The following is a description of a gene set: Binding to a specific upstream regulatory DNA sequence (transcription factor recognition sequence or binding site, located in cis relative to the transcription start site (i.e., on the same strand of DNA) of a gene transcribed by some RNA polymerase. Cis-regulatory sites are often referred to as a sequence motifs, enhancers, or silencers. Mouse Gene Set: GOMF_CIS_REGULATORY_REGION_SEQUENCE_SPECIFIC_DNA_BINDING species: Mus musculus, and this is the list of marker genes: Hoxa2, Zfp942, Zbtb7a, Obox7, Zbtb25, Tcf7l1, Sox17, Rax, Nr3c2 (NCBI Gene Id 17363), Gm12258, Hoxb6, Zfp663, Smc3, Irf1, Zfp853, Klf6, Dmtf1l, Olig2, Etv6, Snapc3, Tbx6, Creb3l2, Hoxa1, Batf, Zfp74, Zfp869, Zfp54, Kdm1a, Tug1, Rest, Dlx1, Gzf1 (GDNF-inducible zinc finger protein 1), Atoh8, Pparg, Zscan21, Zfp704, Hoxc9, Wbp2, Zbtb17, Foxa2, Blvra, Zkscan3, Neurod6, Nr2c2, Nkx2-3, Rel, Notch2, Stk16, Rxrb, Zbtb43, Foxp3, Meox1, Foxp2, Zscan22, Cebpe, Foxd2, Snai1, Foxb2, Yap1, Zbtb14, Pitx3, Tal2 (T cell acute lymphocytic leukemia 2), Nfe2l1 (nuclear factor, erythroid derived 2,-like 1), Evx1, Sox9, Hdac5, Myod1, Atf6, Zfp39, Mtf1, Zbtb2, Otx1, Srebf1, Creb3, Zfp3, Tcf12, Etv2, Hoxd9, Hinfp, Hnf4a, Srf, Onecut1, Ets2, Myog, Sox6, Crem, Ell, Figla, Hmga1, Tfec, Foxc2, Rarg, Onecut2, Zfp507, Hoxd4, Nfe2l3, Bcl11b, Foxn3, Bmal1, Zfp975, Foxe3, Cc2d1b, Mef2b, Atf7, Stat4, Mybl2, Cdx1, Cux1, Myb, Zeb1, Skor2, Zfp444, Zfp446, Hnrnpk, Tgif1, Egr1, Klf1, Pax4, Calcoco1, Neurog3, Rbmxl1, Klf16, Bsx, Mypop, Litaf, Ovol3, Hoxa11, Sars1, Ovol1, Zbtb45, Zfp868, Zfp384, Ubp1, Runx2, Zbtb24, Gm14418, Foxo1, Zfp775, Stat6, Zfp280d (zinc finger protein 280D), Sox1, Mxi1, Bhlhe40, Nacc1, Pasd1, Helt, Clock, Zfp30, Zfp644, Tbx2, Fosl2, Patz1, Pax3, Zfp707, Eef1d, Sp140, Zfp358, Hif1a, Hnrnpu, Smad5, Vax2, Sp6, Lrrfip1, Nfyc, Hdx, Zfp935, Rfx4, Mynn, Zfp984, Thrb, Hdgf, Thap1, Fezf2, Zfp418, Hivep1 (NCBI Gene Id 15271), Esr2, Otx2 (orthodenticle homeobox 2), Zfp53, Msx2, Hmga1b, Zeb2, Six5, En2 (engrailed 2), Stat2, Dmrta1, Zfp612, Tfcp2, Zfp219, Ascl1, Nrf1, Gli3, Zfp286, Nr2e1, Mixl1, Zscan20 (NCBI Gene Id 277652), Foxn2, Hoxb9, Prmt5, Hoxd13, Zfp534, Rora, Ppara, Hsf2, Nkx3-2, Zbtb6 (zinc finger and BTB domain containing 6), Zfp689, Rxra, Prdm16 (NCBI Gene Id 70673), Zkscan14, Hoxd1, Brf1, Zscan4d, Med1, Ccar1, Foxo4 (NCBI Gene Id 54601), Zfp395, Gcm2, Zfp213, Rorb, Prox1, Mxd4, Kdm6b, Nfya, Zfp747l1, Tfap2e, Dach1, Zkscan2, Foxa1, AW146154, Neurog2, Pou4f2 (NCBI Gene Id 18997), Cxxc1, Tfap4, Hoxa3, Zbtb20, Zfp13, Zbtb7c, Gm2381, Hey2, Gm7072 (predicted gene 7072), 4930522L14Rik, Foxa3, Maf1, Gm4767, Mef2d, Zscan26, Zfp128, Zfp143, Zfp560, Mlxipl, Zfp563, Zfp809, Fezf1, Nkx6-1, Hoxa5, Msx1, Zbtb12, Zfp648 (NCBI Gene Id 207678), Tbx22, Plag1, Ski, Mef2a, Zfp937, Nfe2, Zfp985, Wiz, Zbtb1, Hes2, Zfp992, Hoxc4, Gtf2ird1, E4f1, Mtor, Foxf2, Thrap3, Pou1f1, Tiparp, Scrt2, Cebpb, Evx2, Onecut3, Zbtb37, Creb5, Zfp160, Zfp874a, Ascl2, Zfp871, Ikzf2, Zfp341, Zfp683, Glis2, E2f6, Zfp954, E2f7, Thap11, Nr4a1, Nkx2-5, Smad4, Relb, Zfp772, Twist1, Sp3, Fev, Zscan4c, Phox2b, Nfatc2, Dach2, Zfa-ps, Zbtb26, Atoh1 (NCBI Gene Id 11921), Ezh2, Zfp768, Myf5, Zic4, Pou3f2, Nr2f6, Foxn4, Ehf, Tcf15, Isl1, Nr2c1, Prdm5, Zfp141, Zbtb11, Nrl, E2f2, Zik1, Bptf, Tfap2a, Tbx5, Zfp973, Pou3f3, Pax6, Foxd4, Zscan10, Per2, Zfp366, Pou6f1, Fubp1, Zfp970, Zfp946, Sirt1, Cebpa, Ddit3, Zbtb7b, Zfp879, Dmrtc1b, Nkx2-9, Gm19965, Tet1, Rslcan18, Irf3, Smad9, Hoxb5, Klf5 (Kruppel-like transcription factor 5), Zfp980, Vax1, Zfp174, Maff, Gsx1, Nr1i2, Isl2, Ctcf, Nkx1-1, Ep300, Hoxa4, Sohlh1, Rad21, Tead4, Fli1, Zfp988, Nrip1, Nfe2l2, Sall1, Zfp263, Spib, Ascl5 (achaete-scute family bHLH transcription factor 5), Sox3, Rsl1, Bcl6b, Thra, Spz1, Skor1, Mafa, Zfp260, Nkx2-6, Nkx2-1, Zfp773, Hesx1, Zfp623, Zfp1, Zfp583, Hnf4g, Zfp740, Hif3a, Runx1, St18 (suppression of tumorigenicity 18), Dmrt1, Klf10, Tbx10, Nfkb1, Bach2 (NCBI Gene Id 319905), Dmrtc1a, Wt1, Foxl2, Plagl1, Sox13, Zfhx4, Zfp977, Zkscan17, Klf12 (Kruppel-like transcription factor 12), Zfp866, Klf13, Zfp239, Foxe1, Zfp131, Tfeb, Rorc, Hoxb4, Bach1, Foxl1, Arnt2, Hes7, Tbx15, Mafk, Zfp599, Trim24, Egr3, Bhlhe41, Zfp994, Zfp28, Prdm15, Bhlhe23, Spi1, Dbp, Trp73, Zfp354a, Klf9, Zfp87, Zfp354b, Zfp940, Zscan29, Zfp322a, Meis1, Sox2, 5730507C01Rik, Zfp668, Obox3, Zfp846, Irf8, Gtf3c5, Trp63, Hoxa13, Tcfl5, Hes1, Zfp990, Zfp870, Zfp454, Notch4, Foxs1, Hnf1b, Zfp750, Nr2e3, Gm6871, Nr1i3, Mafg, Zfp930, Zfp712, Suz12, Irf2, Hoxd11, Zkscan4, Zfp287, Bmyc, Tcf7l2 (NCBI Gene Id 21416), Pbx1, Zfp280b, Med12 (mediator complex subunit 12), Zfp983, Tfap2b, Tbp, Zfp764, Jun, Mzf1, Prdm11, Gata6, Zfp989, Hoxa9, Zfp865, Stat1, Egr4, Dlx2, Hhex, Crx (cone-rod homeobox), Klf14, Nr2f1, Cdx4, Zfp72, Klf17, Foxo3, Zscan4-ps1, Jmjd8, Zfp82, Grhl1, Emx2, Zfp92, Zfp84, Zscan25, Nhlh2, Zbtb33, Zfp551, Zfp335, Ebf3, Sox18, Hoxc5, Zfp113, Nr1d2, Zfp148, Mecom, Zfp442, Tbx19, H3f3a, Smad3, Zic1, Ncoa2, Pax8, Tcf4, Yy1, Zfp345, Zfp580, Zfp998, Mnt, Gm14403, Zfp456, Zbtb22, Klf8, Zbtb9, Eomes, Zfp575, Pou2f1, Hoxb7, Top1, Zbtb49, Zfhx3 (zinc finger homeobox 3), Zkscan16, Zfp934, Prox2, Nkx6-3, Sox21, Gmeb2, Zfp354c, Hdac6, Zfp960, Glis3, E2f3, Msc, Tet3, Zfp273, Hsf1, Zfp568, Irx2, Med8, Grhl2, Tfdp1, Tbx18, Ikzf3, Foxf1, Ell3, Hmga2, Ctcfl, Neurod1, Nsd1, Hes3, Dmrtc2, Sox11, Glis1, Nfib, Zfp655, Jund, Zfp746, Satb1 (special AT-rich sequence binding protein 1), Zfp1004, Zfp715, Elk3 (ELK3, member of ETS oncogene family), Nr1h4, Zfp280c, Lhx1 (LIM homeobox protein 1), Sox30, Zfp667, Rfx5, Zfp516, Smyd3, Obox1, Usf1, Zfp820, Prrx2, Dhx36, Dhx9, Obox2, Hey1, Hoxc11, Bcl11a, Ell2, Dnmt3a, Gsc2, Smad2, Irf6, Batf2, Ppard, Nkx2-4, E2f4, Irx1, Gata5 (NCBI Gene Id 228988), Zfp110, Nr2f2, Nfkbiz, Tal1, Nkx1-2, Irf7, Kcnip3, Pou4f1, Creb3l3, Bhlha15, Runx3, Notch1, Zfp212, Pou6f2, E2f1, Elk1, Hmgb2, Irf4, Zfp872, Zfp639, Zfp943, Meis2, Cebpd, Tbx4, Yy2, Zfp277, Dmrt2, Hsf4, BC024063, AI854703, Gcm1, Zfp352, Zfp369, Noto, Zfp410, Dlx5, Zfp7, Maz, Dmtf1, Mir208b, Xbp1, Hes6, Irx4, Ikzf5, Nfat5, Zfp513, Zfp995, Foxj1, Sox12, Zfp607a, Atf4, Zfp251, Mybl1, Mitf, Sox8, Foxc1, Mycs, Sp4, Rfx7, Ikzf4, Npas4, Zfp982, Nr5a1, Per1, Tead3, Sox5, Ovol2, Nkx3-1, Pax2, Arx, Gata1, Zfp697, Zkscan7, Pou2f2, Nkx6-2, Snai2, Nr3c1, Zic2 (NCBI Gene Id 57066), Bmal2, Zfp933, Emx1, Nr1h2, Hivep3, Gm32687, Zfp652, Zfat, Myt1l, Zbtb16, Zfp65, Esrrg, Zfp426, Sp7, Pgr, Zfhx2, Sohlh2, Pou3f1, Snapc4, Ikzf1, Myt1, Rfx2, Fos, Zbtb32, Zim1 (NCBI Gene Id 22776), Pitx1, Pbx3, Hdac1, Zfp991, Kdm6a, Nfil3, Nr1d1, Cry1, Satb2, Zbtb8a, Gli2, Zfp296, Irx3, Zbtb39, Elf4, Atf2 (activating transcription factor 2), Cphx1, Zfp987 (zinc finger protein 987), Zfp637, Ets1, Mef2c, Prop1, Arnt, Zfp68, Gm15446, Lyl1, Gm17655, Zfp647, App (NCBI Gene Id 319425, amyloid beta precursor protein), Zfp981, Mycl, Pou4f3, Zfp944, E2f8, Zfp711, Zfp708, Muc1, Zfp1007, Sox7, Brf2, Six4, Gm14434, Mxd3, Zfp536, Insm2, Zfp976, Pax1, Zic3, Klf4, Pdx1, Hand2, Insm1, Hoxd3, Foxj2, Fosb, Smad1 (NCBI Gene Id 17125), Mkx, Irf5, Irx6, Hoxc10, Tcf3, Zfp429, Hlf, Tcf21, Obox5, Ogg1, Prdm1, Nobox, Pitx2, Snai3, Nr1h5, Zscan4e, Hnf1a, Myef2, Nkx2-2, Foxd1, Uhrf1 (NCBI Gene Id 18140), Ruvbl2, Safb, Sox14, Obox8, Myf6, Gata4, Ahr (NCBI Gene Id 193333), Zbtb4, Zfp692, Stat5a, Zkscan5, Klf7, Klf15, Rbmx, Mga, Hoxd10, Pax7, Pknox1, Preb, Foxq1, Zfp932, Zfp1006, Pou5f1, Esrra, Zfp281, Zfp874b, Zgpat (NCBI Gene Id 229007), Rfx8, Meox2, Hoxc13, Sp8, Zfp362, Mesp2, Usp3, Tbx21 (T-box 21), Pax5, Atf3, Creb3l1, Sp2, Zfp184, H2az1, Zfp202 (NCBI Gene Id 80902), Stat5b, Carf, T, Zbtb38, Hdac2, Zfp966, Zfp408, Zfp941, Neurod2, Nhlh1, Nfyb, Zfp607b, Ptf1a, Lef1, Zfp58, Foxj3, Scrt1, Npas2, Mafb, Junb, Hoxc6, Ddn, Klf3, Neurod4, Rbpjl, Zfp182, Ebf4, Gm5141, Zscan5b, Hdac4, Rfx6, Jdp2, Hoxb2, Zfp850, Creb1, Six1, Nr4a3, Etv4 (NCBI Gene Id 217208), Gmeb1, Zfp947, Hbp1, Nfatc3, Zfp979, Spic (Spi-C transcription factor (Spi-1/PU.1 related)), Tbx1, Zscan12, Gfi1b, Kcnh8, Zfp236, Esrrb, Nfic, Nr5a2, Hoxb1, Hoxa6, Tef, Usf2, Sub1, Nr6a1, Chd7, Dmrta2, Zfp397, Nfkb2, Zscan4-ps2, Zfp677, Sp9, Zfp873, Dlx3, Gabpa, Zfp821, Hoxb13, Neurog1, Zfp2, Zfp334, Maf, Tead1, Zfp628, Pou3f4, Zfp433, Esr1, Foxi1, Rbpj, Zfp951, Atf6b, Mesp1, Zfp386, Prdm4, Heyl, Zfp455 (zinc finger protein 455), Zfp958, Sox15, Gata2, Mycn, Chd2, Tbr1, Zscan4b, Cdx2, Skil, Rara, Zscan4f (NCBI Gene Id 665902), Msgn1 (NCBI Gene Id 56184), Zfp523, Hcfc1, Zfp691, Zfp382, Myc, E2f5, Zfp1010, Foxd3, Creb3l4, Platr25, Nacc2, Atoh7, Zfp867, Rarb, Nfatc1, Foxp1 (NCBI Gene Id 73231), Zbtb34, Nlrc5, Gm14443, Tbx20, Zfp449, Zfp719, Mybbp1a, Zic5, Zfp758, Batf3, Zfx, Tfe3, Nanog, Rreb1, Kdm2b, Cc2d1a (coiled-coil and C2 domain containing 1A, NCBI Gene Id 212139), Zfp217, Zfp12, Hand1, Nfix, Klf11, Phox2a, Hoxb3, Nfia, Max, Bhlhe22, Klf2, Foxk1, Ago1, Gata3, Nr1h3, Tfcp2l1, Cebpg, Foxi2, Ebf1, Zfp324, Rfx3, Egr2, Sp1 (NCBI Gene Id 68485), Gm614, Foxl3, Gm35315, Six3, Zfp24, Foxb1, Tbx3 (T-box 3), Tcf7, Rbbp4, Fosl1, Foxp4, Bcl6, Uty, Olig1, Zfp420, Ebf2, Dmrt3, Zfp616, Hivep2, Grhl3, Gm14399, Zkscan6, Zfp472, Zfp42, Six6, Zfp59, Zfp97, Cux2, Zfp493, H3f3b, Elf3, Irx5, Lhx2, Sox4, Zkscan1, Six2, Hoxa10, B020011L13Rik, Gfi1, Tead2, Zfp317, Ciart, Nfatc4, Smarca4, Elk4, Mxd1, Dlx4, Rela, Zfp14, Foxo6, Sox10, Rfx1, Erg, Zfp950, Pou5f2, Zfp710, Zfp747, Obox6, Mta1, Zfp189, Gm3604, Hes5 (hes family bHLH transcription factor 5), Foxk2, Vdr (NCBI Gene Id 22337), Zscan4-ps3, Zfp956, Pax9, Atf1, Rxrg, Zfp524, Olig3, Stat3, Pou2f3, Irf9, Dmrtb1, Etv1, Tfap2c (NCBI Gene Id 98784), Nkrf, Nr4a2, Tardbp, Prrx1, Cdk9, Gsc, En1, Rad23b, 2010315B03Rik, Zfp764l1, Dlx6, Sry, Zfp367, Epas1, Rex2, Gli1, Zscan2 (NCBI Gene Id 22691), Hoxa7, Elf1, Dmrtc1c1, Trp53, Scx, Zfp664, Ar, Zfp85, Sp5, Zkscan8, Srebf2